Given this list of marker genes IQGAP1, GDI1, GIPR, CPNE3, SMPD1, ACER1, SLC25A23, INHBB, ITPR3, MICU1, PRKAA1, CRHBP, SLC25A24, ECT2, LCN6, KCNMB4, ITPKC, HNRNPD, PKD2, S100A16, PPIF, RASA4, NRXN1, ALOX5AP, D2HGDH, ADCY1, SCN5A, CAV1, JUN, CALM3, CPNE2, AMELX, RASA4B, KCNIP2, ITPKA, ALOX15, PENK, FOSB, GUCA1A, CASR, WNT5A, SYT1, CAPN3, AQP3, ADCY8, P2RX7, BRAF, THBS1, ANXA11, RASAL1, MICU2, ITPKB, TRPC1, EEF2K, CALM2, CPNE9, VPS54, PEF1, MCOLN1, HCN1, CARF, CLIC4, CACNG2, HPCA, TRPM2, TTN, AKR1C3, KCNMB2, KCNB1, ENTPD6, MNAT1, TRPC3, CPNE7, CPNE6, RYR3, DPEP1, KCNMB1, CALM1, CASQ2, MICU3, CAMK2D (calcium/calmodulin dependent protein kinase II delta), NEUROD2, RYR1, CHP2, PDCD6, CPNE4, CPNE8, MTTP, TUBA1A (NCBI Gene Id 95407), KCNMB3, AANAT, RYR2, DUSP1, TRPV6, CCND1, LCE1D, EDN1, CACYBP, FGG, CPNE5, MEF2A, LGMN, RASGRP2, MEF2C, TXNIP, ADGRV1, ANXA7, FGB (NCBI Gene Id 2244), ASPH, GRXCR1, HOMER1, SLC25A13, KCNH1, JUNB, SUCNR1 (succinate receptor 1), NCSTN, PPP3CA, NFATC2, PRKAA2, SEC31A, FGA, PLCG2, NEDD4, ADD1, P2RX5, ABCC9, AHCYL1 (adenosylhomocysteinase like 1), APP, MT-CYB, ADAM9, GUCA1ANB-GUCA1A, KCNQ3, NLGN1, CPNE1, ENDOG, FOS, SLC25A12, JUND, TNNT2, STIM1, KCNMA1, here is a description of the gene set: Any process that results in a change in state or activity of a cell or an organism (in terms of movement, secretion, enzyme production, gene expression, etc.) as a result of a calcium ion stimulus. Human Gene Set: GOBP_RESPONSE_TO_CALCIUM_ION species: Homo sapiens